Given this list of marker genes SGCE, SNTB2, DMD (NCBI Gene Id 548327), SSPN, SGCA, CAV3, SNTG2, SNTA1, SGCZ, UTRN, SNTB1, SGCB, SGCG, SNTG1 (NCBI Gene Id 54212), PGM5, SGCD, KRT19, DAG1, here is a description of the gene set: Human Gene Set: GOCC_DYSTROPHIN_ASSOCIATED_GLYCOPROTEIN_COMPLEX studied in species Homo sapiens A multiprotein complex that forms a strong mechanical link between the cytoskeleton and extracellular matrix; typical of, but not confined to, muscle cells. The complex is composed of transmembrane, cytoplasmic, and extracellular proteins, including dystrophin, sarcoglycans, dystroglycan, dystrobrevins, syntrophins, sarcospan, caveolin-3, and NO synthase.